The following is a description of a gene set: Reactome Pathway: RHOA GTPase cycle part of: RHO GTPase cycle This event has been computationally inferred from an event that has been demonstrated in another species.<p>The inference is based on the homology mapping from PANTHER. Briefly, reactions for which all involved PhysicalEntities (in input, output and catalyst) have a mapped orthologue/paralogue (for complexes at least 75% of components must have a mapping) are inferred to the other species. species: Mus musculus electronically inferred by orthology from the curated human pathway, and this is the list of marker genes: Arhgap44, Dock2, Rhpn1, Ktn1, Faf2, Rtkn, Arhgef10, Arhgef10l, Fam13a, Hmox2, Gmip, Vav1, Bcap31, Actc1, Arhgap28 (Rho GTPase activating protein 28), Arhgef12, Arap1, Arhgap19 (NCBI Gene Id 71085), Farp1, Arhgap42, Arhgap11a, Arhgap9, Arhgap10, Ngef, Arhgap22, Pkn1, Cav1, Arhgef7, Arhgap45, Arhgap40, Vangl1, Arhgef3, Racgap1, Pgrmc2, Plekhg3, Arhgef1, Atp6ap1, Tmem87a, Lbr, Stard8, Arhgef15 (NCBI Gene Id 442801), Prex1, Flot2, Lman1, Scfd1, Pik3r2, Flot1, Arhgdib, Stard13, Emc3, Stk10, Arhgef17, Dlc1, Jup, Depdc1b, Acbd5, Mcam, Arhgap18, Ophn1, Arhgap8, Arhgap26, Ccdc115, Aaas, Tagap (T cell activation Rho GTPase activating protein), Pcdh7, Plekhg6